Given this list of marker genes GNS, B4GAT1, B3GNT7, ST3GAL3, B3GNT2, ST3GAL6, GLB1, SLC35D2, CHST1, CHST5 (carbohydrate sulfotransferase 5), ST3GAL1 (ST3 beta-galactoside alpha-2,3-sialyltransferase 1), ST3GAL2, ST3GAL4, CHST2, CHST6, B3GNT4, B4GALT4, B3GNT3, here is a description of the gene set: studied in species Homo sapiens Human Gene Set: GOBP_KERATAN_SULFATE_PROTEOGLYCAN_METABOLIC_PROCESS The chemical reactions and pathways involving keratan sulfate proteoglycans, which consist of a core protein linked to a keratan sulfate glycosaminoglycan. The keratan sulfate chain is composed of the repeating disaccharide unit beta-(1,4)-N-acetyl-D-glucosamine-beta-(1,3)-galactose, both of which can be sulfated.